The following is a description of a gene set: A cell-cell junction that seals cells together in an epithelium in a way that prevents even small molecules from leaking from one side of the sheet to the other. Human Gene Set: GOCC_TIGHT_JUNCTION species: Homo sapiens, and this is the list of marker genes: OCLN, PARD6A, JAML, FRMD4B, JAM2, CDK4, PATJ, TJP3, APC, CLMP, TGFBR1, CYTH1, PLXDC1 (NCBI Gene Id 57125), CLDN18, LSR, RAP2B, MAPK15, CLDN15, NHS, MXRA8, PRKCZ, OCEL1, CLDN10, MARVELD2, USP53, CLDN4 (NCBI Gene Id 1364), ECT2, AOC1, TJAP1, CLDN7, STRN, CCND1, CLDN20, CLDN1, EPHA2, LUZP1, SAPCD2, PARD6G, CXADR, CLDN12, PRKCI, MAGI1 (membrane associated guanylate kinase, WW and PDZ domain containing 1), IGSF5, CTNNB1, RPGRIP1L, PARD3, MAP3K1 (NCBI Gene Id 4214), AFDN (NCBI Gene Id 92217), CLDN24, CLDN14, AMOTL2, CYTH2, LIN7B, WNK3, CLDN5, WWTR1, JAM3, NPHP1, DLG1, ILDR2, FZD5, DSG3, CYTH3, C1QTNF5, SYNPO, FRMPD2, SH3BP1, CRB3, TRAF4, CLDN34, UBN1, ESAM, F11R, AMOT (NCBI Gene Id 23340), WNK4, LIN7A, PMP22, ARHGEF2, CGNL1, RAB13, CLDN17, SYMPK, EPCAM, TJP2, SIPA1L3, TJP1, FRMD4A, CLDN16, PALS1, CGN, CLDN8, PDCD6IP, MARVELD3, YAP1, CLDN11, CDH5, BVES, RAP2C, CLDN25, MPP7, ARHGAP17, SHROOM2, CLDN19, MTDH, NPHP4, MPDZ, TBCD, VAPA, ACTB, ASH1L, EPB41L4B, PARD3B, ADCYAP1R1, PARD6B, MAGI3, POF1B, CLDN9, MICALL2, ANK3, GJA1, CLDN2, MAGI2, AMOTL1, YBX3, CLDN3, RAPGEF2, ILDR1, CLDN22, CLDN23, CLDN6, VASP, CCDC85C, EPPK1, LIN7C, RIGI, DLG3